Given this list of marker genes IGLV2-8, IGLV3-1, AHCYL1, IGKV1-16, IGHV3-13, IGKV2-30, IGHV3-48, IGKV2D-40, GNB5, GNAI1, IGKV1D-12, ADCY1, GNAZ, IGKV4-1, IGLC2, FCGR2A, IGLV7-43, IGKV1-39, IGLV2-14, IGKV3-11, GNG12, MAPK14, GNG3, ADCY2, IGKV1D-33, CYSLTR2, GNG11, IGKV1-17, PLCG1, ADCY7, PRKACG, IGLV3-27, ADCY3, IGHV3-23, ITPR3, YES1, SYK (NCBI Gene Id 6850), GNG10, ADAM17, IGLV2-23, IL6, ITPR1, SRC, CREB1, IGLV1-51, FGR, IGHV2-5, FCGR3A, IGKV1D-16, IGHV3-33, GNG7, IGHV3-30, PRKX, FCGR1A, CALM1, GNG5, IGHV2-70, MYH9, ADCY5, IGKV1D-39, IGHV3-11, IGKV1-5, IL10, PRKAR2B, FURIN, GNAI2, PLK2, GGT5, IGLV1-44, GNB2, IGKV3D-20, GNGT1, PRKAR2A, RHBDF2, IGHV4-59, IGLV3-21, IGKV1-12, DPEP1, IGLV3-19, PRKACB, DPEP2, CYSLTR1, IGHV3-7, GNB4, IGHV4-39, IGHV3-53, GNB1, IGKV1-33, CD3G, IGLV6-57, PRKAR1B, IGLV3-25, CD247, ADCY4 (NCBI Gene Id 196883), GNG2, PRKACA, GNB3, IGLV1-47, GNAI3, IGKV3-20, GNAT3, IGHV1-46, IGKV2D-28, ITPR2, IGHV4-34, ADCY8 (NCBI Gene Id 114), CD163, GNG4, IGHG4, IGKV5-2, PLCG2 (NCBI Gene Id 5336), ADCY6 (NCBI Gene Id 23320), IGLC3, ADORA2B, HCK, GNG8, IGKV3-15 (immunoglobulin kappa variable 3-15), IGLV2-11, IGKV2D-30, IGHG1, LYN, PRKAR1A, IGKV2-28, GNAS, IGLV1-40, GNGT2, GGT1, GNG13, IGHV1-2 (immunoglobulin heavy variable 1-2), IGHV1-69, ADCY9, FYN, IGHG2, here is a description of the gene set: Human Gene Set: REACTOME_ANTI_INFLAMMATORY_RESPONSE_FAVOURING_LEISHMANIA_PARASITE_INFECTION species: Homo sapiens Anti-inflammatory response favouring Leishmania parasite infection